Given this list of marker genes Phactr4, Tfap2a (NCBI Gene Id 21418), Sox11, Arid1a, Pax2, Aldh1a1, Aldh1a3, here is a description of the gene set: The invagination of the optic vesicle to form two-walled indentations, the optic cups, that will go on to form the retina. This process begins with the optic vesicle becoming a two-walled structure and its subsequent shape changes. It does not include the fate commitment of cells to become the pigmented retina and the neural retina. An example of this process is found in Mus musculus. studied in species Mus musculus Mouse Gene Set: GOBP_OPTIC_CUP_MORPHOGENESIS_INVOLVED_IN_CAMERA_TYPE_EYE_DEVELOPMENT